The following is a description of a gene set: Mouse Gene Set: GOBP_FACE_DEVELOPMENT The biological process whose specific outcome is the progression of a face from an initial condition to its mature state. The face is the ventral division of the head. studied in species Mus musculus, and this is the list of marker genes: Mapk3, Msx1, Rab3gap1, Rara, Prickle1, Tiparp, Dlx5, Itga4, Nipbl, Ep300, Bbs4, Dkk1, Map2k1, Plekha1, Mkks, Tgfb3, Zic3, Sgpl1, Pax9, Wnt5a, Nog, Crispld1, Lef1, Csrnp1, Tbx1, Map2k2, Stra6, Ankrd11, Scx, Ptpn11, Tfap2a, Aldh1a3 (aldehyde dehydrogenase family 1, subfamily A3), Chd7, Crebbp, Hoxb3, Twist2, Raf1, Asph, Crispld2, Rarg (retinoic acid receptor, gamma), Cdk2ap1, Col1a1, Zfand5, Pdgfra, Specc1l, Srf (NCBI Gene Id 224821), Schip1, Tgfb2, Zfp640, Zfp950, Kat6a, Ski, Mmp2, Tcf7l2, Braf, Sox3, Lrp6, Rras, Ednra, Mapk1, Grhl2, Tgfb1, Arid5b, Aldh1a2